Given this list of marker genes NTHL1, UNG, MBD4, TDG, OGG1, APEX1, SMUG1 (NCBI Gene Id 23583), MPG, MUTYH, here is a description of the gene set: part of: Resolution of Abasic Sites (AP sites) Following cleavage of the damaged base, DNA glycosylase is displaced by APEX1, an AP endonuclease. Reactome Pathway: Displacement of DNA glycosylase by APEX1 studied in species Homo sapiens